The following is a description of a gene set: studied in species Homo sapiens part of: Signaling by NOTCH1 in Cancer Reactome Pathway: FBXW7 Mutants and NOTCH1 in Cancer FBXW7 (FBW7) is a component of the SCF (SKP1, CUL1, and F-box protein) ubiquitin ligase complex SCF-FBW7 which is involved in the degradation of NOTCH1. Loss of function mutations in FBXW7 are frequently found in T-cell acute lymphoblastic leukemia and are mutually exclusive with NOTCH1 PEST domain mutations., and this is the list of marker genes: CUL1, FBXW7, RBX1, SKP1, NOTCH1 (NCBI Gene Id 54781)